The following is a description of a gene set: species: Homo sapiens Enables the transfer of zinc (Zn) ions from one side of a membrane to the other. Human Gene Set: GOMF_ZINC_ION_TRANSMEMBRANE_TRANSPORTER_ACTIVITY, and this is the list of marker genes: SLC30A7, SLC30A3, SLC39A9, SLC39A11, SLC30A6, SLC39A10, SLC11A2, SLC30A8, SLC30A9 (NCBI Gene Id 10463), SLC39A2, SLC39A13, SLC39A12, SLC39A5, SLC39A4, SLC30A10, SLC30A2, SLC30A1, SLC39A7, TRPM7, SLC39A8, SLC30A5, SLC39A14, SLC30A4, SLC39A1, SLC39A6, SLC39A3